The following is a description of a gene set: Genes up-regulated in FE-8 cells (fibroblasts) upon treatment with azacitidine. Human Gene Set: LUND_SILENCED_BY_METHYLATION species: Rattus norvegicus from publication Lund P, Weisshaupt K, Mikeska T, Jammas D, Chen X, Kuban RJ, Ungethüm U, Krapfenbauer U, Herzel HP, Schäfer R, Walter J, Sers C (PMID 16568090) Silencing of gene expression by methylation of CpG islands in regulatory elements is frequently observed in cancer. However, an influence of the most common oncogenic signalling pathways onto DNA methylation has not yet been investigated thoroughly. To address this issue, we identified genes suppressed in HRAS-transformed rat fibroblasts but upregulated after treatment with the demethylating agent 5-Aza-2-deoxycytidine and with the MEK1,2 inhibitor U0126. Analysis of gene expression by microarray and Northern blot analysis revealed the MEK/ERK target genes clusterin, matrix metalloproteinase 2 (Mmp2), peptidylpropyl isomerase C-associated protein, syndecan 4, Timp2 and Thbs1 to be repressed in the HRAS-transformed FE-8 cells in a MEK/ERK- and methylation-dependent manner. Hypermethylation of putative regulatory elements in HRAS-transformed cells as compared to immortalized fibroblasts was detected within a CpG island 14.5 kb upstream of clusterin, within the clusterin promoter and within a CpG island of the Mmp2 promoter by bisulphite sequencing. Furthermore, hypermethylation of the clusterin promoter was observed 10 days after induction of HRAS in immortalized rat fibroblasts and a clear correlation between reduced clusterin expression and hypermethlyation could also be observed in distinct rat tissues. These results suggest that silencing of individual genes by DNA methylation is controlled by oncogenic signalling pathways, yet the mechanisms responsible for initial target gene suppression are variable., and this is the list of marker genes: HES1, SDC1, H3-3B (NCBI Gene Id 3021), MAP1LC3A, RNF4, ADAM17, CLU, AMD1, HMOX1, SDC4 (NCBI Gene Id 6385), NOTCH1, ODC1, PLPP1 (phospholipid phosphatase 1), TMEM101 (transmembrane protein 101), POLR2H, TIMP2